The following is a description of a gene set: studied in species Homo sapiens from publication Liberzon A, Birger C, Thorvaldsdóttir H, Ghandi M, Mesirov JP, Tamayo P (PMID 26771021) Genes encoding proteins involved in glycolysis and gluconeogenesis. Human Gene Set: HALLMARK_GLYCOLYSIS, and this is the list of marker genes: HSPA5, PYGB, KDELR3, PLOD1, TKTL1, B3GALT6, ME1, B3GNT3, AK3, ENO2, KIF20A, PFKP, GAPDHS, B4GALT4, IER3, PFKFB1, PRPS1, TXN, ECD, GPC4, SPAG4, SRD5A3, GMPPA (NCBI Gene Id 29926), GNPDA1, ABCB6, GPC1, GOT2, LDHA, SLC35A3, PGK1, PGAM1 (NCBI Gene Id 95038), PAM, IDH1, CHST12, NDUFV3, HDLBP, COL5A1, GOT1, SLC16A3, B3GAT3, TFF3, UGP2, ALDOB, B3GAT1, HOMER1, STC1, TPST1, ELF3, DCN, TGFBI, QSOX1, NANP, CHST1, ALDH7A1, PPIA, GLRX, CENPA, GAL3ST1, HK2, VEGFA, PAXIP1, CHPF2, MIF, CTH, ZNF292, IDUA, GALE, PPP2CB, MIOX, MERTK, CASP6, PHKA2, LCT, PDK3, POLR3K, EGLN3, CHPF, B4GALT7, MDH1, HS6ST2, TGFA, VCAN, NT5E, EXT1, G6PD, MXI1, PSMC4, PGLS, CHST2, PYGL, IL13RA1, CAPN5, ME2, HMMR, BIK, ISG20, P4HA1, ARPP19, SLC25A13, ERO1A, GYS1, COPB2, RARS1, DDIT4, PKM, NASP, CITED2, CYB5A, FKBP4, HAX1, VLDLR, AGL, GMPPB, CHST6, NOL3, GUSB, ALDOA, RRAGD, SOD1, ALG1, KIF2A, FUT8, SDC2, SLC37A4, PMM2, ALDH9A1, RPE, B4GALT2, TPI1, RBCK1, GALK1, DLD, GPC3 (glypican 3), SDC3, PGM2, GPR87, EXT2, IGFBP3, ARTN, SDHC, EFNA3, GFPT1, DEPDC1, MED24, CD44, CDK1, AKR1A1, ENO1, B4GALT1, TPBG, MDH2, PLOD2, COG2, STMN1, DPYSL4, ANGPTL4, EGFR, SAP30, ADORA2B, PPFIA4, GLCE, BPNT1 (3'(2'), 5'-bisphosphate nucleotidase 1), DSC2, LDHC, NSDHL, PKP2, CLDN3, AGRN, CLDN9, CACNA1H, ANKZF1, GNE, FAM162A, CHST4, IRS2, CLN6, MPI, GFUS, SOX9, FBP2, MET, GYS2, PC, AK4, SLC25A10, SDC1, TALDO1, XYLT2, CXCR4, LHX9, STC2, LHPP, GALK2, P4HA2, AURKA, HS2ST1, NDST3, PGAM2, GCLC (NCBI Gene Id 2729), ANG